The following is a description of a gene set: Human Gene Set: REACTOME_TNF_SIGNALING TNF signaling studied in species Homo sapiens, and this is the list of marker genes: OTUD7B, USP4, ADAM17, BIRC2, SPPL2A, TAB3, ULK1, CASP8, IKBKG, SPATA2, RIPK1, USP21, RACK1, BIRC3, CHUK (NCBI Gene Id 1147), CLIP3, TRADD, UBC, UBE2D3, TNFAIP3, TAB1, FADD, UBE2D2, TAX1BP1, SPPL2B, CFLAR, OTULIN, TNFRSF1A, UBE2D1, IKBKE, TNF, RBCK1, SHARPIN, SMPD3, OTUD1, MIB2, TRAF1, BAG4, IKBKB, USP2, TAB2, OPTN, UBB, STUB1, NSMAF, UBE2L3, RPS27A, RNF31, TBK1, SMPD2, MAPKAPK2, MADD, CYLD, TRAF2, UBA52, MAP3K7, XIAP